The following is a description of a gene set: Human Gene Set: REACTOME_SIGNALING_BY_RECEPTOR_TYROSINE_KINASES studied in species Homo sapiens Signaling by Receptor Tyrosine Kinases, and this is the list of marker genes: PAK3, ATP6V1B1, POLR2A, PGR, ID1, ID2, CTNNA1, PPP2CA, PRKACG, JAK3, LAMA3, GTF2F2, BCAR1, UBB, RAPGEF1, STAM, ATP6V1D, PTBP1 (polypyrimidine tract binding protein 1), TRIB1, FGFR2 (fibroblast growth factor receptor 2), STAT1, UBA52, ATP6V0A1, COL4A5, SH3GL2, CREB1, RPS6KA3 (NCBI Gene Id 6197), PIK3R4, CBL (NCBI Gene Id 867), FLRT3, MKNK1, CHEK1, DNM3, EPN1, NCF4, DNM1, NRG1, DOCK7, GRIN2B, IDE, TNK2, SPINT2, TNS3, IGF2, LAMB1, STAT5B, FGFR1, PAG1, ATP6V0A2, RHOA, JUND, SPINT1, RICTOR, PSEN2, SHC2, SOS1, NGF, NCOR1, TLR9, ITPR1, ATP6V1H, GTF2F1 (NCBI Gene Id 2962), HIF1A, ATP6V1G2, FGF1, HSPB1, GAB2, COL1A1, PLAT, PTPRK, COL4A3, SH2B2, POLR2J, LAMC1, REST, BRK1, MATK, ATP6V0D2, AHCYL1, PRKCD, CD274, SPRED1, RAB4A, ARF6, PPP2R5D, COL9A3, HGS, GIPC1, FLT1, LAMA4, AP2M1, NELFB, FGFBP1, LAMC2, MYCN, POLR2H, PIK3CB, ATP6V1G1, GABRG3, UBC, YAP1, PXN, ATP6V0A4, AXL, KIDINS220, ADCYAP1R1, CAV1, EGR3, FLRT1, YWHAB, ITGAV, THBS4, NCBP1, FAM83A, COL5A2, ATP6V0E1 (ATPase H+ transporting V0 subunit e1), MAPK14, HGF, MEMO1, F3, FOSB (FosB proto-oncogene, AP-1 transcription factor subunit), RALGDS, LAMB3, VEGFB (vascular endothelial growth factor B), COL5A1, GABRA1, ALK, RPS6KA5, DOCK3, ATP6V1C2, PCSK5, ROCK1, MAP2K2 (NCBI Gene Id 85511), PRKCZ, EGFR, FGFBP2, AKT1, ASCL1, DUSP4, ANOS1, FLT3LG (NCBI Gene Id 2323), COL6A2, NCK2 (NCBI Gene Id 8440), ROCK2, JAK2 (NCBI Gene Id 3717), DUSP3, SPHK1, ERBB4, ATP6V0C, CTNNB1, STAM2, ESR1, MEF2C, APH1B, FYN, NTRK3, FER, CLTA, ITGB1, MMP9, VRK3, RPS27A, BRAF, ATP6V0D1, PTPN6, ADAP1, LCK, CDC37, FGF18, POLR2I, NTRK2, RIT2, MST1R, CSK, EPGN, NTF4, LRIG1, S100B, TIAL1, GRB2, PTPRF, LAMC3, LAMA2, PSEN1, SPRED2, COL24A1, ABI2, STUB1, SPRY1, COL4A1, FGF16, MYC, PLG, ELMO1, ESRP2, TCIRG1, FGF7, CYFIP2, KITLG, RALA, VAV1, FGF8, RANBP10, TIA1, TEC, POLR2D, AKT2, NAB2, ESRP1, PRR5, THBS1, POLR2F, FGF19, ERBB3, ATP6V1C1, WASF3 (WASP family member 3), CDH5, CTSD, TIAM1, NAB1, GFAP, PGF, RIT1, ITGA3, HBEGF, VAV3, DUSP7, COL11A1, CLTC, TCF12, FGF23, PPP2CB, SOCS1, COL6A3, ADAM10, FGF5, USP8, CHD4, MAP2K1, PDE3B, HRAS, EGR1, FGF9, LAMA1, NCBP2, RANBP9, COL4A4, WASF2, KLB, IRS4, ADAM12, ADORA2A, CDK5, GABRB1, PRKCA, THBS3, PDGFRB (NCBI Gene Id 5159), GABRB2 (NCBI Gene Id 2561), ID4, FOSL1, SHC1, STMN1, KRAS, YES1, DOCK1, PIK3C3, VEGFA, FRS2, FLT4, COL6A1, ATP6V1F, ITGB3, VAV2, COL9A2, FLRT2, CSN2, ARHGEF7, SH2B3, FGF4, FGF3, ELK1, PDPK1, PTPN3 (NCBI Gene Id 5774), ATP6V0B, ERBB2, PDGFB, CDK5R2, COL11A2, ACTB, GRAP2, MEF2A, MAPK13, ITGA2, MAPK11, IGF1, PDGFC, MUC20, GGA3, EPS15, PCSK6, RNF41, EPS15L1, IL2RG, PTPN11, RPS6KA2, COL5A3, HGFAC, TNS4, MDK, APH1A, RASA1, LAMA5, PRKCE, CRK, HNRNPH1, INSR, ADCYAP1, HDAC1, COL3A1 (collagen type III alpha 1 chain), VEGFD, ALKAL2, GABRB3, CYBA, BAIAP2, ITPR2, PIK3CA, SPRY2, ALKAL1, SOCS6, GRB10, CXCL12, PRKCB, COL27A1, NCF2, NRG2, RRAD, MAPK3, FGF17, PTPRU, SIN3A, AP2A2, INS, ITPR3, NCKAP1, LAMB2, FGFR4, BDNF (brain derived neurotrophic factor), ATP6V0E2, ELMO2, MAPK12, FAM83D, CYFIP1, THEM4, NRP1, ATP6V1B2, MST1, EGR2, RALB, FURIN, PPP2R1A, NRAS, PRKACA, AKT3, PTN, ACTG1, PAK1, PTPRO, FGF22, ADAM17 (ADAM metallopeptidase domain 17), IGF1R, RAP1B, PTK2B, NTF3, HNRNPF (heterogeneous nuclear ribonucleoprotein F), NRP2, MAPK1, BTC, AAMP, KL, COL4A2 (collagen type IV alpha 2 chain), PPP2R1B, LYN, CILP, WASF1, NCF1, SPARC, KDR, NRG3, MAP2K5, ABI1, EP300, POLR2E, RBFOX2, WWP1, DLG4, TGFA, CUL5, AP2S1 (adaptor related protein complex 2 subunit sigma 1), SRC, FRS3, COL6A5, AP2B1, CALM1, APOE, PTK2, PSENEN, GAB1, AREG, POLR2C, FOS, NCKAP1L, VGF, FAM83B, MAPK7, HDAC2, DNAL4, EREG, STAT5A, NOS3, FGF2, NCSTN, COL2A1, FGFR3, IRS1, MAPKAP1, JUP, RPS6KA1, TPH1, FGF20, ATP6V1G3, PTK6, MAPKAPK3, RAB4B, VEGFC, BAX, PDGFRA, MEF2D, PRKACB, PIK3R2, ATP6V1E1, ATF2, LTK, NCK1, SGK1, PTPN18, CDK5R1, FES, DNM2, EGF, MXD4, FLT3, FGFBP3, THBS2, SPP1, GRAP, FN1, JUNB, PLCG1, DIAPH1 (NCBI Gene Id 1729), ATF1, POLR2L, ERBIN (NCBI Gene Id 55914), RAC1, HPN, CMA1, SHC3, CTNND1, COL9A1, GABRQ, FGF10, HNRNPM, DUSP6, POLR2B, HSP90AA1, CYBB, NRG4, GRB7, SHB, STAT6, AP2A1, TGFBR3, MTOR, PTPRJ, PDGFD, FGFRL1, RAP1A, SH3KBP1, MAPKAPK2 (NCBI Gene Id 9261), MET, ATP6V1A, LYL1, ATP6V1E2, SH3GL3, ITCH, STAT3, DNMT1, SH2D2A, PTPN12, KIT, CDC42, FGF6 (NCBI Gene Id 2251), EGR4, PTPN1, SRF, WWOX, POLR2K, PTPRS, PIK3R1, ARC, PAK2, TAB2, TRIB3, NEDD4, ATP6AP1, PDGFA, CRKL, HNRNPA1 (NCBI Gene Id 780920), IRS2, ID3, COL1A2, NTRK1, GALNT3, SH3GL1, PTPN2, PIK3R3, PTPRZ1, HDAC3 (histone deacetylase 3), POLR2G, GABRG2, PRDM1 (NCBI Gene Id 639), MLST8, COL6A6